Given this list of marker genes AKR1A1, GLA, FUCA1, AKR1B10, AKR1C3, SULT1C4, CBR4, SLC34A1, AKR1B1, GBA1, AKR7A2, FUCA2, AKR1C4, NAGA, GBA2, AKR1C1, GBA3, AKR1C2, here is a description of the gene set: studied in species Homo sapiens Human Gene Set: GOBP_GLYCOSIDE_METABOLIC_PROCESS The chemical reactions and pathways involving glycosides, compounds in which a glycosyl group is substituted into a hydroxyl, thiol or selenol group in another compound.